Given this list of marker genes HPD, EGR4, STXBP1, FCAR, CMIP, EEPD1, SLC8A2, here is a description of the gene set: Genes predicted to be targets of miRBase v22 microRNA hsa-miR-1268a, hsa-miR-1268b in miRDB v6.0 with MirTarget v4 prediction scores > 80 (high confidence targets). from publication Chen Y, Wang X (PMID 31504780) Human Gene Set: MIR1268A_MIR1268B species: Homo sapiens